Given this list of marker genes POLR2L, ZFP36L2 (ZFP36 ring finger protein like 2), COX6C, MFAP4, HSD3B7, TUBA1B, RAP1A, AXL, LSP1, MT-ND1 (mitochondrially encoded NADH:ubiquinone oxidoreductase core subunit 1), SOD1, NTRK2, SDCBP, UAP1, SSR3, GPX4, DAB2, IL6ST, ANXA1, MIR4435-2HG, PROCR, KRT10, JAG1, MT-ND3, ENO1, S100A4, DDAH2, COL12A1, PRDX5, S100A11, PLTP, BLOC1S1, OAZ1, LRP1, TRIO, TIMM13 (translocase of inner mitochondrial membrane 13), CYTOR, PLPP1, NDUFB1, CDK4, DBN1, COL1A1, GLUL, VIM, PCOLCE2, EMP3, COL6A1, PRRX1, S100A13, PXN, ANXA4, FGFR1, CSTB, TMEM106C, RNF13, MFAP5 (microfibril associated protein 5), AP3S1, C1R, DBI, HSP90AA1, SELENOS, RNF7, GSN, RBPJ, CLU, F10, SEC61G, DYNLT1, TNFAIP2, SCARA5, FTH1, LDHA, TMCO1, FN1, SELENOM, NCL, TCEAL9, NUPR1, MRPS6, PI16, COL1A2, YBX3 (Y-box binding protein 3), KGD4, TXN, CTSK, LIMA1, CREB5, DCN, PKM, CCN5, CAVIN3, MPC1, CKS1B, PPIC, EFHD1, SERPING1, ATP6V0E1, ITGB1BP1, RTN4, NTM, MXRA8, PLAC9, BZW1, HIGD1A, PTGIS, RPS27L, IGFBP6, MARCKS, SSB, S100A10, ARL4D, OSTC, C3, CCN1, HTRA1, DDR2, TMEM176B, DEFB1, MGP, OST4, GTF2H5, CD55, EBF1, TGFBR3, MYDGF, ACTG1, MGST1, ELN, CD99, CPE, TYMP, CD63, DST, MT-ND2, CHRDL1, MMP2, C17orf58, NBPF10, ATP2B1, AHNAK, S100A6, VKORC1 (NCBI Gene Id 79001), SDC2, OAT, NEGR1, HSBP1, ANXA7, SEMA3C, MTCH1, TUBB, HNRNPF, ANXA2, DGUOK, SERPINF1, SEC63, MT-CO3, COL14A1, PHPT1, NID1, GFPT2, CD248, FABP3, CELF2 (CUGBP Elav-like family member 2), FILIP1, COL6A3, SERF2, CRIP1, C1QTNF3, ABI3BP, PLA2G2A, ALDOA, MT-CYB (NCBI Gene Id 4519), PRG4, LAMB2, LMNA, LINC01133, DYNC1H1, FSTL1, MRPL51, HTRA3, GPX3, ARF4, ISLR, CYBRD1, FBLN5, FBLN2, CCDC80, JUND, CALU, ALDH1A3, RBMS3, SLPI, TIMP1, TIMP3, TFPI, FXYD1 (FXYD domain containing ion transport regulator 1), ARL6IP5, BEX3, RPL36AL, DDX24, NAA38, PAM, ADD3, PTPRA, NOTCH2, SMIM14, RBMS1, GAS1, RNH1, LTBP4, EIF1, TMEM258, GYPC, HSPA1A, MEG3, CFD, EFEMP1, GLUD1, SEC61B, MRPL33, KLF4, FTL, ATP5PD, AKAP12, LOXL1, COL6A2, ACKR3, COL3A1, CAST, FHL1, TIMP2 (NCBI Gene Id 7077), MT1E, PMP22, TPPP3, VCAN, MT-ND4, TUBA1A, RAB32, PDGFRA, BEX4, TAF9, NOVA1, MYOF, RSL1D1, FNDC1, NDFIP1, ADAMTS5, LAPTM4A, GLIPR2, UGP2, VIT, OSR2, FBN1, MMP14, MYADM, FBLN1, APCDD1, TMEM109, IDS, C1S (complement C1s), CST3, GSTO1, PDGFRL, ITGB5, SVBP (small vasohibin binding protein), CLIC1, ANXA5, OLFML2A, ANXA11, UBXN4, PCOLCE, BIN1, EIF5, HSPE1, SH3BGRL3, TNXB, MEDAG, PSAP, H2AJ, RBM39, IGFBP5, TPT1, SPRR2B, RPLP0, ADI1, GPNMB, ZYX, OLFML3, ACAT1, here is a description of the gene set: Human Gene Set: RUBENSTEIN_SKELETAL_MUSCLE_FBN1_FAP_CELLS studied in species Homo sapiens from publication Rubenstein AB, Smith GR, Raue U, Begue G, Minchev K, Ruf-Zamojski F, Nair VD, Wang X, Zhou L, Zaslavsky E, Trappe TA, Trappe S, Sealfon SC (PMID 31937892)